The following is a description of a gene set: Genes under-expressed in KRT19-positive hepatocellular carcinoma. from publication Villanueva A, Hoshida Y, Battiston C, Tovar V, Sia D, Alsinet C, Cornella H, Liberzon A, Kobayashi M, Kumada H, Thung SN, Bruix J, Newell P, April C, Fan JB, Roayaie S, Mazzaferro V, Schwartz ME, Llovet JM (PMID 21320499) In approximately 70% of patients with hepatocellular carcinoma (HCC) treated by resection or ablation, disease recurs within 5 years. Although gene expression signatures have been associated with outcome, there is no method to predict recurrence based on combined clinical, pathology, and genomic data (from tumor and cirrhotic tissue). We evaluated gene expression signatures associated with outcome in a large cohort of patients with early stage (Barcelona-Clinic Liver Cancer 0/A), single-nodule HCC and heterogeneity of signatures within tumor tissues. studied in species Homo sapiens Human Gene Set: ANDERSEN_LIVER_CANCER_KRT19_DN, and this is the list of marker genes: ACSL5, KGD4, CRYL1 (crystallin lambda 1), SERPING1, PTMS, SERPIND1, PGRMC1 (NCBI Gene Id 10857), G6PC1, UGT2B15, SERPINA3, NFIX, GNMT, ALDH1A1, PCYOX1, HMGCS2, HAO2, SLC31A1, SEL1L, SIAH2, TMEM140, TNIP1, SLC25A25, LEAP2, AFM, ALDOB, AK3, PTGR1, PEMT, GRHPR (NCBI Gene Id 9380), HSD3B7, PAPSS2 (3'-phosphoadenosine 5'-phosphosulfate synthase 2), GSTM1, CYP3A4, EPHX1, AMACR, TESK2, ETFDH, CYP4F2, HPD, APOA5, CEBPB, CPQ, TFR2, DECR2, ABCC6, UGT2B17, AOX1, CIDEB, CPT2, SLC41A2, RETSAT, GPT, UGT2B10, ANG, MGST2, KHK, ARMC5, ADRA1B, DPYS (NCBI Gene Id 1807), PDE2A, GPX2, PRDX6, PC, PFKFB1, PKLR, ITIH1, AKR7A3, C8G, HADH, SAA4, SELENBP1, ALAD, SLC22A7, DIO1, BAAT